Given this list of marker genes C17orf58, DTWD1, WFS1, SPRYD3, UCK2, TRMT6, FXYD2, VGLL1, NTAQ1, CLDN10, VWA5A, IFFO2, LARP4, TNKS1BP1, SLC45A3, ASIC5, BSDC1, CHCHD1, SCHIP1, PDZD8, CRYM, SEC13, GGNBP2, TYMS, LRATD2, LPAR4, TLN1, HSD17B12, HDHD3, DMWD, ACER2, SLC9A2, NOL12, RGS18, FAF2, SPRYD7, PRPH2, ACSBG1, PPM1A, FLYWCH2, NTHL1, COX4I1, PBXIP1, MECR, ALPK1, NSMCE2, CD34, PDE8A, INSIG2, GATA2, MYBPC2, AGA, LRRK2, NUCB2, CD28, CDK7, PIK3C2A, NBEA, GALNT3, PTGIR, FABP3, PRRC2C, NGDN, ITGAM, ANO8, LNX1, AHNAK, LRCH1, ANKRD34A, MAFG, MCAM (melanoma cell adhesion molecule), MAP6, ITFG2, HNRNPH1, TXNDC17, ARL1, APPL1, APBB2, SFXN4, EPS15L1, SMPD5, DAPK1, BTG3, LPAR3 (NCBI Gene Id 23566), MRPS33, MRM3, NFIX, MEF2C, CZIB, ZNF32, FN1, CDCP1, NCKAP1, IL11RA, GRM3, ALKBH7, RHPN1, ST3GAL5, DNAJB12, MEF2A, NDUFAF8, RAB27A, CA6, CRTC2, HOMER3, ATP1B4, F2RL3, NDUFAF3, ABHD18, HEXB, ZNF334, RSPH9, PHLPP1, NEK9, PARD6A, FBXL21P, DLGAP4, PTPRS, NBDY, IRF4, MSANTD4, ODC1, ARMC3, GTF2IRD2, PPP1R3C, TMEM88, ABL1, ADAMTS4, CA7, TINAG, ANG, VEZF1, SLC25A38, DNAJC21, TRAPPC2B, RYR1, TRAF2, GOLGB1, EIF3G, FBP1, SPTBN1, LTC4S, KCNJ3, MBD2, RPS3A, FOXRED2, MROH9, FBXO8, ISCA2, SFRP2, EFR3B, FAM220A, MAMDC2, NHERF2, GALNT9, PADI2, ARHGAP42, AQP9, RIOX2, ACP1, RAD23A, ZNF276, STARD6, SMCO4, HNRNPA0, NUDCD2, AGGF1, RASGRP3, ADAM8, DENND1B, VEGFA, BMX, PSD3, CNNM2, GPR107, HMGA2, METTL26, NCS1, ATP11B, NEMF, SLA, EHMT1, TBC1D25, MFSD6, ACAP1, RNF222, ANGPT1, CACNA1A (NCBI Gene Id 773), CRACDL, HSPA5, PUDP, TRIM68, CFAP43, SKA2, CCSAP (NCBI Gene Id 126731), CLDND1, SPCS3, MME, CKAP4, SDC3, here is a description of the gene set: IL-10 or IL-6 stimulation of control 129xC57BL/6 murine bone marrow derived macrophages in the presence of LPS. We used microarrays to detail the global programme of gene expression changes in response to IL-6 or IL-10 stimulation in the presence of lipopolysaccharide. BMDMs were isolated from control, IL-6-/-, and IL-10-/- mice on a 129XBL/6 mixed background mice and differentiated in the presence of CSF-1 for 6-7 days. Cells were scraped and plated in 6 well plates at 2x10e6/well. Cells were washed with complete DMEM and rested for 1-2 hr before stimulation with combinations of IL-10 (10 ng/ml), IL-6 (2 ng/ml) or LPS (100 ng/ml) for 45 min or 180 mins. Complete biological replicates were performed. Human Gene Set: GSE5589_IL6_KO_VS_IL10_KO_LPS_STIM_MACROPHAGE_180MIN_UP from publication El Kasmi KC, Holst J, Coffre M, Mielke L, de Pauw A, Lhocine N, Smith AM, Rutschman R, Kaushal D, Shen Y, Suda T, Donnelly RP, Myers MG Jr, Alexander W, Vignali DA, Watowich SS, Ernst M, Hilton DJ, Murray PJ (PMID 17114459) studied in species Homo sapiens Genes up-regulated in bone marrow-derived macrophagesat 180 min stimulation by LPS: IL6 knockout versus IL10 knockout.